The following is a description of a gene set: Human Gene Set: GOBP_POSITIVE_REGULATION_OF_CELL_CYCLE_G2_M_PHASE_TRANSITION Any signaling pathway that activates or increases the activity of a cell cycle cyclin-dependent protein kinase to modulate the switch from G2 phase to M phase of the cell cycle. species: Homo sapiens, and this is the list of marker genes: RAD51B, HSPA2, PBX1, PHOX2B, CDK1, MTA3, CDC7, STOX1 (NCBI Gene Id 219736), VPS4B, SMARCD3, CCNB1, RRM1, BRD4, DYRK3 (dual specificity tyrosine phosphorylation regulated kinase 3), ATAD5, CDK4, RAB11A, RCC2, WNT10B, CDC25A, RRM2B, FBXO5, CDC25C, RAD51C, CDC25B, DBF4B, SIN3A, NPM1, CCND1, DTL